Given this list of marker genes AGR2, AKAP5, CNST (consortin, connexin sorting protein), STAC3, PLS1, ITGA3 (NCBI Gene Id 4454), RAMP3, LRP1, RACK1, PIAS1 (protein inhibitor of activated STAT 1), EIF4G1, ACSL3, PRKCI, EGFR, CLN3, CLIP3, NKD2, STAC, ATP2C1, STAC2, COMMD1, ATP2B4, CIB1, SPTBN1, DLG1, ZDHHC2, EPB41, PKP1, DPP10, PRNP, WNT3A, ZDHHC5, GPER1, CACNG2, TREM2, RANGRF, PTPN9, STX3, PPP1R9B, MIR223, RER1, ITGB1, EPB41L2, AKT1, TNF, SORBS1, KIF5B, PIK3R1, LGALS3, EFCAB7 (NCBI Gene Id 84455), NRXN1, GPSM2, PGRMC1, CNPY4, PRKCE, ANXA13, VPS35, EPHA2, WNK3, ARF6 (ADP ribosylation factor 6), VIL1, SQSTM1, ZDHHC8, RHOG, IFNG, EPHA3, NUMA1, RAB11FIP2, EZR, SNCA, STX4, EPHB2, ARHGEF16, PRKCH, PDPK1, RAB11A, GNAI1, RAB38, here is a description of the gene set: Human Gene Set: GOBP_POSITIVE_REGULATION_OF_PROTEIN_LOCALIZATION_TO_CELL_PERIPHERY species: Homo sapiens Any process that activates or increases the frequency, rate or extent of protein localization to cell periphery.